The following is a description of a gene set: Any process that decreases the rate, frequency or extent of sequestering of triglyceride. Triglyceride sequestration is the process of binding or confining any triester of glycerol such that it is separated from other components of a biological system. species: Mus musculus Mouse Gene Set: GOBP_NEGATIVE_REGULATION_OF_TRIGLYCERIDE_STORAGE, and this is the list of marker genes: Osbpl8, Pnpla2, Abhd5 (abhydrolase domain containing 5), Ppara (NCBI Gene Id 399624), Pparg, Trem2